The following is a description of a gene set: from publication Chen Y, Wang X (PMID 31504780) studied in species Homo sapiens Genes predicted to be targets of miRBase v22 microRNA hsa-miR-4784 in miRDB v6.0 with MirTarget v4 prediction scores > 80 (high confidence targets). Human Gene Set: MIR4784, and this is the list of marker genes: EXOC8, PABIR1, CDK17, DKK2, PDPR, LRRC20, DNAAF11, PABIR2, SNAP25, GEMIN4, ANKS1A, LYPLA1, NSD2, SH3PXD2A, RNF44, WNT1, MS4A13 (membrane spanning 4-domains A13), SLC35F1, VRK3, RHOA, BAZ2A, SLC25A17, CD59, MMP11 (NCBI Gene Id 4320), ZDHHC9, UHMK1, IKZF4, PARP11, GDF5, TMED10, GFRAL, RORA, FMNL3, IGF2R, NAV2, DLG1, DOCK8, ONECUT2, CCL13, RSPO4, AP3S2, PGR, ZNF652, DTX4, JPH4, ATL2, CCDC127, FIBIN, POU3F3, TBR1, RFX5, USB1, PSMD11, TSC22D4 (TSC22 domain family member 4), PDX1, MTMR11, ZFYVE1, ZBTB39, SLC24A2, MTCL2, NCEH1, UBE2QL1, SLC25A13, PRG2, HLA-DQA1, NAIF1, PRP4K, SLC25A36, FUT8, RNF39, MS4A1, COPG2, RCL1, CD302, NDUFA4, PSD2, POU2F2, MYO1D, SSBP2, UBXN7, BRIP1, SIX3, NFIC, ODF1, ENDOD1, RIC3, INO80D, NRN1, TAOK2, ENOSF1, PRKCA, DAB2, MMADHC, TAGLN3, TRIM66, PRKRA, BLMH, CSGALNACT1, PBX2, ARPIN-AP3S2, TULP4, LY75-CD302, E2F2, AGPAT1, IGF1R, IFFO2, RHOH, KANK2 (NCBI Gene Id 55598), SOX6, FAM168A, CCNI2, KAT7, ARHGEF39, SOCS6 (NCBI Gene Id 9306), CSRP3, GPR65, FCGR1BP, GRIN2A, ADAM28, APCDD1, XPO7, CNTFR, BAAT, KIAA1549L, KLHL29, PITPNA, FOXJ2, GPR61, PRDM15 (PR/SET domain 15), SLC34A1, SGCZ, FTHL18P, MED18, CHRDL1, FRZB, CACNB4, HBP1, TNS1, CLSPN, ZBTB44, BASP1 (brain abundant membrane attached signal protein 1), KLRG1, SH3TC2, TRIM21, DSC3, TREM1, FBXO31, MTPN, ATG16L2, ACSBG2, LUZP1, FBXO42, RTL5